Given this list of marker genes Mief1, Pgam5, Ddhd2, Prkn, Mief2, Irgm2, Mff, Marchf5, Rala, Bnip3, Dnm1l, Mcu, Pink1, Dcn, Irgm1, Igtp, Mul1, Kdr, Ddhd1, Fis1, Ralbp1, Spire1, Aurka (aurora kinase A), Vps35, here is a description of the gene set: Mouse Gene Set: GOBP_POSITIVE_REGULATION_OF_MITOCHONDRIAL_FISSION species: Mus musculus Any process that increases the rate, frequency or extent of mitochondrial fission. Mitochondrial fission is the division of a mitochondrion within a cell to form two or more separate mitochondrial compartments.